Given this list of marker genes BNC2, NAP1L1, CASTOR2, DLL3, PRRC2B, KDM2A, EI24, PIKFYVE, THTPA, ARRB2, MPP2, COL27A1, VKORC1L1, CCDC120, SPTLC2, DDX6, DGKK, RIMS4, TMEM86A (transmembrane protein 86A), PPP3R2, PAFAH1B2, ERGIC1, IL19, ZBTB14, SLC1A7, PLPPR5, ZDHHC22 (zinc finger DHHC-type palmitoyltransferase 22), NPTXR, AGAP1, SAMD14 (sterile alpha motif domain containing 14), ZC3H13, CLSTN2, SDC4, CLTC, IPO5, XKR4, PROX1, FOXG1, CHD2, PCSK6, NFIA, TMEM164, RCAN2, VLDLR, CELF2, HMGXB3 (HMG-box containing 3), HP1BP3, TMEM72, PHACTR1, CLOCK, NUP35, PPM1A, KCTD15, ZBTB10, RTN4, SLC25A37, CALHM2, C3orf70, HDAC1, EXOC6, BEAN1, MATN2, VGLL4, CLIC5, ADRA1A, TTC17, PRPF19, RAPH1, CTDSPL2, CCNK, UBE2K, TMEM129, PCSK1, DOK1, KLHL14, SINHCAF, ICA1L, C2orf88, TNRC6B, SH3BP5, BOK, TBC1D22B, PPP2R5B, LSAMP, NFAT5, NTRK3, ILDR2, FAM218A, NALF2, LSM2, EPB41L1, TRIM65, SAMD7, SQLE, CPEB2, RELT, PTPN4, EPHB4, KPNA6 (NCBI Gene Id 23633), PLK2, SEMA4C, POU2F1, here is a description of the gene set: from publication Chen Y, Wang X (PMID 31504780) Genes predicted to be targets of miRBase v22 microRNA hsa-miR-3127-3p in miRDB v6.0 with MirTarget v4 prediction scores > 80 (high confidence targets). studied in species Homo sapiens Human Gene Set: MIR3127_3P